The following is a description of a gene set: The process in which the anatomical structures of a pharyngeal arch artery is generated and organized. The pharyngeal arch arteries are a series of six paired embryological vascular structures, the development of which give rise to several major arteries, such as the stapedial artery, the middle meningeal artery, the internal carotid artery and the pulmonary artery. studied in species Homo sapiens Human Gene Set: GOBP_PHARYNGEAL_ARCH_ARTERY_MORPHOGENESIS, and this is the list of marker genes: EDN1, TGFB2, BMP4, HES1, EDNRA, BMPR2, FOLR1, ADGRF5, MEGF8, BMPR1A, NOG (noggin)